Given this list of marker genes Smarca2, Grem1, Sphk2, Actr3b, Grid1, here is a description of the gene set: Genes predicted to be targets of miRBase v22 microRNA mmu_miR_5134_3p in miRDB v6.0 with MirTarget v4 prediction scores > 80 (high confidence targets). studied in species Mus musculus Mouse Gene Set: MIR_5134_3P from publication Chen Y, Wang X (PMID 31504780)